The following is a description of a gene set: Genes down-regulated in comparison of dendritic cells (DC) exposed to T. gondii versus DCs exposed to 50 worms/well B. malayi. Monocyte-derived dendritic cells (DC) and macrophages (MΦ) generated in vitro from the same individual blood donors were exposed to five different pathogens, and gene expression profiles were assessed by microarray analysis. Responses to Mycobacterium tuberculosis and to phylogenetically distinct protozoan (Leishmania major, L. donovani, Toxoplasma gondii) and helminth (Brugia malayi) parasites were examined, each of which produces chronic infections in humans yet vary considerably in the nature of the immune responses they trigger. species: Homo sapiens Human Gene Set: GSE360_T_GONDII_VS_B_MALAYI_HIGH_DOSE_DC_DN from publication Chaussabel D, Semnani RT, McDowell MA, Sacks D, Sher A, Nutman TB (PMID 12663451), and this is the list of marker genes: HCCS, ERP29, EPN2, CAMK1, KCNS3 (potassium voltage-gated channel modifier subfamily S member 3), LYL1, PNPLA6, APOC1, GPR45, DNASE2, HEXA, S100A4, PECAM1, RCBTB2, XRCC1, MYH9, F13A1, ARHGAP26, CDR2, ABCA6, TGFA, SPOCK1 (NCBI Gene Id 6695), KMT2D, CHN2, ADAM12, CD164, CPVL, ATXN1, RNF44, PRCP, CLIP2, CAST, VCL, IFFO1, PNISR, PRPSAP2, ABCG1, ZNF124, NDUFS3, DGKZ, P2RY14, NPTN, PLCG2, TRAPPC3, MAPK12, MAF, GARS1, SMAGP, NPAS3, BEX4, CDHR1, MACROH2A1, HLA-E, GGA3, HERPUD1, TXNIP, PPP6R2, TBL2, AIFM1, LPCAT4, GATD3, TMEM59, EPHX2, ARK2N, NIPAL3, PALM, HEXB, CSNK1G2, ZMIZ2, TM4SF4, FBXL5, RAB5C (RAB5C, member RAS oncogene family), TES, TMT1A, EGR2, ASTN1, ITPR2, TKT, IGHA1, MKRN1, ERF, PDIA4, YWHAB, CRABP2, LAIR2, BAP1, MAFK, SHB, CDK5, OVOL2, LOXL2, RIN2, CHMP2B, ALDH3A2, FOLR2 (NCBI Gene Id 2350), ADD1, SPON1, ADCY7, RRP1B, CD1A, TRAPPC12, FKBP8, RNF6, LRP1, KCTD12, ZCCHC24, STX16, ALOX5, ABCB4, TUSC2, USP22, MPO, SCG2, EXOSC9, DOK2, GPC1 (NCBI Gene Id 2817), ZBTB1, ACTR3, LMO2, SCGB1D2, PEG10, MGST2, PIP4K2B, TGOLN2, KIAA0232, ZNF507, MBTPS1 (membrane bound transcription factor peptidase, site 1), ITPK1, AP1S2, RXRA, USP6, CNOT8, SEMA3A, ASIC1, HBBP1, ADORA3, SERINC5, WDR1, ODF2, CORO2A, PLA2G15, RGS19 (NCBI Gene Id 10287), CLEC2B, PINK1, MAPK14, EMILIN1, INPP5D, ELL, CD1E, CTNNAL1, RAB11FIP2, AHCY, SERTAD2, LPIN1, LAMA4 (laminin subunit alpha 4), KCNB1, HHEX, ETV5, IFT20 (intraflagellar transport 20), CD1B, TLR5, QPRT, AMPD1, PRNP, CASR, DUSP3, SLC29A2, RLN2, TPM1, ARHGEF18, PRKACB, HR, ZMIZ1, NRGN, SDC2, IDH1, CES2, HABP2, OSBPL1A, EVI5, MAU2, SYNE1, HFE, IQCE, RUNDC3B, DAPK1, RNASE6 (NCBI Gene Id 6039), DUSP11, LILRA2, MSR1, PPP1R13B, STX10, SLC1A5, SLC25A12, CACNA1E, IL33, ST3GAL5, STAC, LINC01587, BRPF1